The following is a description of a gene set: SMAC, XIAP-regulated apoptotic response Mouse Gene Set: REACTOME_SMAC_XIAP_REGULATED_APOPTOTIC_RESPONSE species: Mus musculus, and this is the list of marker genes: Casp7, Septin4, Xiap, Diablo, Casp3